The following is a description of a gene set: part of: Signaling by EGFR in Cancer Signaling by EGFR is frequently activated in cancer through genomic amplification of the EGFR locus, resulting in over-expression of the wild-type protein. species: Homo sapiens Reactome Pathway: Signaling by Overexpressed Wild-Type EGFR in Cancer, and this is the list of marker genes: EREG, EPGN, EGF, BTC (betacellulin), AREG, HBEGF, EGFR, TGFA